Given this list of marker genes MIR182, MIR638, BMP4, MIR26A1, MIR20A, MIR302C, MIR424, DOCK4, MIR448, IGFBP5, DDR2, MIR503, PAK1, MIR362, MIR451A, GNA12, MEF2C, PRKG1, TPM1, PTPN1, ADAMTS1, MIR214, MIR15A, MIR665, NF1, MIR143, MIR218-1, SSH1, MAP3K7, MIR140, MIR146A (NCBI Gene Id 406938), MIR1298, DDIT3, DOCK7, DOCK5, ADIPOQ, MIR221, MIRLET7B, XBP1, MIR499A, MIR21, MIR135B, FAT1, MIR137, GRB10, MDM2, FGF9, MYOCD, TERT, NR4A3, PDGFB, MIR34A, NFE2L2, MIR223 (NCBI Gene Id 407008), here is a description of the gene set: studied in species Homo sapiens The orderly movement of a vascular associated smooth muscle cell from one site to another. Human Gene Set: GOBP_VASCULAR_ASSOCIATED_SMOOTH_MUSCLE_CELL_MIGRATION